The following is a description of a gene set: Human Gene Set: REACTOME_TRANS_GOLGI_NETWORK_VESICLE_BUDDING trans-Golgi Network Vesicle Budding species: Homo sapiens, and this is the list of marker genes: DNM2, CLVS1, PICALM, BLOC1S3, NAPA, DNASE2, DNAJC6, SNX9, VAMP2, BLOC1S1, M6PR, FTH1, NECAP1, TPD52L1, ARRB1, VAMP7, BLOC1S4, AP4S1, AP3B1, ACBD3, GAK, GBF1, TPD52, HSPA8, TXNDC5, PIK3C2A, CLVS2, GOLGB1, CLINT1, AP3S1, AP1S2, SH3GL2, ARF1, TGOLN2, AP1B1, TFRC, FTL, CHMP2A, AP1G2, AP1M2, TBC1D8B, SNAPIN, CLTB, SNX5, DTNBP1, AP4B1, IGF2R, AP4E1, AP1S3, APP, AP1G1, CTSZ, CPD, HIP1R, SH3D19, BLOC1S6, OCRL, SORT1, CLTA, AP1M1, VAMP8, HGS, AP1S1, PUM1, RAB5C, GNS, SNAP23, SNX2, CLTC, STX4, AP4M1, YIPF6